Given this list of marker genes BAIAP3, SNPH, SYN1, SLC1A3, ABAT, GABRA2, CADPS, STX1A, COPB2, SYNJ1, GAD2, MAOA, CCL3, SNAP25, GAD1, here is a description of the gene set: Human Gene Set: MODULE_563 species: Homo sapiens Genes in the cancer module 563.